The following is a description of a gene set: studied in species Homo sapiens Genes up-regulated in comparison of peripheral blood mononuclear cells (PBMC) from patients with type 1 diabetes at 1 month after the diagnosis versus those at 4 months later. from publication Kaizer EC, Glaser CL, Chaussabel D, Banchereau J, Pascual V, White PC (PMID 17595242) Human Gene Set: GSE9006_1MONTH_VS_4MONTH_POST_TYPE_1_DIABETES_DX_PBMC_UP Objective: We hypothesized that type 1 diabetes (T1D) is accompanied by changes in gene expression in peripheral blood mononuclear cells (PBMCs) due to dysregulation of adaptive and innate immunity, counterregulatory responses to immune dysregulation, insulin deficiency and hyperglycemia. Research Design and Methods: Microarray analysis was performed on PBMCs from 43 patients with newly diagnosed T1D, 12 patients with newly diagnosed type 2 diabetes (T2D) and 24 healthy controls. One and four month follow-up samples were obtained from 20 of the T1D patients. Results: Microarray analysis identified genes differing in expression between newlydiagnosed T1D patients and controls at a false discovery rate of 0.05. Changes in expression of interleukin-1β (IL1B), early growth response gene 3 (EGR3), and prostaglandin-endoperoxide synthase 2 (PTGS2) resolved within four months of insulin therapy and were also observed in T2D suggesting that they resulted from hyperglycemia. With use of a knowledge base, 81/genes could be placed within a network of interrelated genes with predicted functions including apoptosis and cell proliferation. IL1B and the MYC oncogene were the most highly-connected genes in the network. IL1B was highly overexpressed in both T1D and T2D, whereas MYC was dysregulated only in T1D. Conclusion: T1D and T2D likely share a final common pathway for beta cell dysfunction that includes secretion of interleukin-1β and prostaglandins by immune effector cells, exacerbating existing beta cell dysfunction, and causing further hyperglycemia. The results identify several targets for disease-modifying therapy of diabetes and potential biomarkers for monitoring treatment efficacy., and this is the list of marker genes: CTSZ, KIAA0232, DIP2A, CBX6, UPP1, MAP3K20, WWP2, NLRP3, GRAMD1B, CD83, OR7E24, CTRL, ACOT9, ALOX5, FUT4, EGLN3, PLXNC1, NAA11, DEFB1, MYBBP1A, ATG2A, ENSG00000237250 (NCBI Gene Id 401987), MGAM, CEACAM8, TMEM254, PLPPR4, RBMS1, MTF1, IFI30, TAS2R4, ANXA3, INPP5A, MAGEB3, TNNI2, CRYBG3, TAX1BP3, SLC39A9, ICAM4, HERC2P3, ADGRA2, ENC1, PTX3, FIG4, CTAGE1, PRKD1, CREM, CD2BP2, SPRED2, DNAJC1, EYA1, ZNF287, LIN7A, TMEM255A, MAF, LETM1, SPTLC2, GPC5, RFX4, SRGAP2, TBC1D17, P2RY2, ARHGEF16, SLC19A1, MIR22HG, AQP9, ZBP1, TSPAN9, SAT1, TRIM29, LUM, DOCK2, FAM13A, HIC2, TCIRG1, RASSF9, SLC30A9, CARS2, SUSD5, ZNF280B, KLHL36, IL33, SNORA21, MMP8, IFIT3, MNT, GRAMD4, RPL37A, SYCP1, R3HCC1, GNG10, DHCR24, PIGT, GPR137B, NAMPT, MTARC2, NADSYN1, NFKBIE, MCUR1, TNFAIP6 (NCBI Gene Id 7130), ARHGAP26, SGK1, TRIB1, DOCK5, PIM1, COX16, FLRT3, ASPM, ZNF394, RXRA, CYP3A7, MUC7, KAZALD1, BMP2, SCCPDH, PYGL, PABPC1, EMILIN2, TFRC, GUCY1A1, LRRFIP2, CCNJ, OR3A1, TRDN, TENT5A, TULP2, CAPN3, MME, TRIL, PTP4A1, SCO2, CPPED1, NPC2, SLC22A4, DNAJC2, KIR3DX1, MRAS, BCL2A1, SERPINA1, OBSL1, ADM, NUFIP1, PDCD1LG2, LINC02981, KITLG, MAFF, CXCL1, CHAF1A, S100P (S100 calcium binding protein P), B3GNT4, TNF, IL1R2, KBTBD11 (kelch repeat and BTB domain containing 11), MYL5, TALDO1, TLR1, CAMK2N1, TPMT (thiopurine S-methyltransferase), EFCAB11, TEX2, LDLR, NOC2L, NFKBIA, TYR, HLX, SMURF1, IRF1, PIWIL1, TNFRSF8, USP13, PCSK1, NID2, GNG12, ABCB11, NECTIN3, AEN, GPR12, VNN2, SCD5, NUP93, BCL6, KPTN, FPR1, STX4, DLX6, AATF, TIAL1, ATF4, GCNT4, KLF4, GMDS, ADCK2, GNAQ, IER3, HK3, RAP2C (NCBI Gene Id 57826), IMPDH1, COL8A2